The following is a description of a gene set: Mouse Gene Set: GOBP_POSITIVE_REGULATION_OF_EATING_BEHAVIOR Any process that activates or increases the frequency, rate or extent of eating behavior. studied in species Mus musculus, and this is the list of marker genes: Ghrl (ghrelin), Oprk1, Sgip1, Npy, Ghsr, Mtor